The following is a description of a gene set: Bleeding within the vitreous compartment of the eye. Vitreous hemorrhage Human Gene Set: HP_VITREOUS_HEMORRHAGE studied in species Homo sapiens, and this is the list of marker genes: FZD4, ESAM, SMC5, RS1, BAP1, LRP5, CTNNB1, BEST1, SF3B1, RB1, CAPN5, NDP, TSPAN12, ZNF408, GNAQ, CYSLTR2, PROC, GNA11